Given this list of marker genes MMP24 (NCBI Gene Id 10893), FAM83C, MYH7B, AAR2, GDF5, SPAG4 (sperm associated antigen 4), MAP1LC3A (NCBI Gene Id 84557), NCOA6, RBM12, TP53INP2, CEP250 (NCBI Gene Id 11190), EPB41L1, GGT7, EDEM2, NFS1, EIF6, PROCR, PIGU, UQCC1, GSS, ROMO1, DYNLRB1, ERGIC3, ACSS2, SCAND1, DLGAP4, CNBD2, PHF20, TRPC4AP, CPNE1, RBM39, here is a description of the gene set: from publication Nikolsky Y, Sviridov E, Yao J, Dosymbekov D, Ustyansky V, Kaznacheev V, Dezso Z, Mulvey L, Macconaill LE, Winckler W, Serebryiskaya T, Nikolskaya T, Polyak K (PMID 19010930) studied in species Homo sapiens Human Gene Set: NIKOLSKY_BREAST_CANCER_20Q11_AMPLICON Genes within amplicon 20q11 identified in a copy number alterations study of 191 breast tumor samples. A single cancer cell contains large numbers of genetic alterations that in combination create the malignant phenotype. However, whether amplified and mutated genes form functional and physical interaction networks that could explain the selection for cells with combined alterations is unknown. To investigate this issue, we characterized copy number alterations in 191 breast tumors using dense single nucleotide polymorphism arrays and identified genes with copy number gain organized into 30 amplicons. Amplicons were distributed unequally throughout the genome. Each amplicon had distinct enrichment pattern in pathways, networks, and molecular functions, but genes within individual amplicons did not form coherent functional units. Genes in amplicons included all major tumorigenic pathways and were highly enriched in breast cancer-causative genes. In contrast, genes with somatic mutations in breast cancer were distributed randomly over the genome, did not represent a functionally cohesive gene set, and were relatively less enriched in breast cancer marker genes. Mutated and gained genes did not show statistically significant overlap but were highly synergistic in populating key tumorigenic pathways including transforming growth factor beta, WNT, fibroblast growth factor, and PIP3 signaling. In general, mutated genes were more frequently upstream of gained genes in transcription regulation signaling than vice versa, suggesting that mutated genes are mainly regulators, whereas gained genes are mostly regulated. ESR1 was the major transcription factor regulating amplified but not mutated genes. Our results support the hypothesis that multiple genetic events, including copy number gains and somatic mutations, are necessary for establishing the malignant cell phenotype.